The following is a description of a gene set: Human Gene Set: GOBP_HOMOPHILIC_CELL_ADHESION_VIA_PLASMA_MEMBRANE_ADHESION_MOLECULES The attachment of a plasma membrane adhesion molecule in one cell to an identical molecule in an adjacent cell. species: Homo sapiens, and this is the list of marker genes: PCDHB15, DSG1, PCDH18, DSC3, PCDHA9, PCDHB1, PCDHB2, CELSR2, CDH26, PCDH7, FAT3, NECTIN1, PCDHB6, PTPRG, HMCN1, CDH9 (cadherin 9), CDH1 (NCBI Gene Id 999), PCDHB3, PCDHB7, ESAM, PKD1 (NCBI Gene Id 5310), CEACAM5, PCDH19, PCDHGB3, HMCN2, CDH4, CDH17, PCDHB13, IGSF21, CADM2 (cell adhesion molecule 2), PCDHA5, PCDHGC3, PCDHGA1, PCDHGB1, PTK7 (NCBI Gene Id 5754), PCDHA1, NPTN, AMIGO1, CDH5, DSG3, CDH8, PVR, PCDHB5, CDH16, PCDHGA6, PTPN23, PCDH15, PCDHB18P, CEACAM1, CELSR3, CDH3, ROBO2, NECTIN4 (nectin cell adhesion molecule 4), PCDHA4, RET, PCDHGA9, PCDH8, FAT2, CLSTN3 (calsyntenin 3), PCDHB8, NECTIN2, PIK3CB, PCDHGB5, PCDHGA4, CDHR5, PCDHA13, PLXNB3, PCDH10, PCDHGA12, PCDHB16, MYOT, EMB, PCDHB10, PCDHA7, ROBO4, CDH24, PCDHGA11, IGSF11, PCDHGB4, PCDHA6, DCHS1, PCDHA10, PCDHGB6, PCDHAC2, CDH20, CDH6, PCDH12, PCDHGA2, CDH11, KIRREL3, DSC1, ROBO1, DSCAM, CDHR1, CDHR2, CDH13, ROBO3, PECAM1, BSG, PCDHB4, PCDHB9, SDK2, CDH18, PCDHAC1, MYPN, CLSTN2, TENM3, CDH12, PCDHGA7, PLXNB2, CADM4, PCDH1, PCDHB11, CDH10, ITGB1, CDHR4, DSC2, PCDHGA3 (protocadherin gamma subfamily A, 3), CDH23, PCDHGC4, AMIGO2, PCDHB14, CDH2, FAT4, DSG2, FAT1, PCDH9, PCDHA11, DSCAML1, CNTN6, PCDH11X, DSG4, TRO, MPZL2, PCDHGA10, PTPRM, PTPRR, PCDHA8, PCDHA3, IGSF9, CD84, CNTN4, CDHR3, PCDH11Y, PCDH17, SDK1, CDH15, PCDHGA5, CDH22, PCDHGB2, PCDHGA8, PTPRT, CEACAM6, PCDHB12, CNTN2 (NCBI Gene Id 6900), DCHS2, CELSR1, PCDHA12, L1CAM, CLSTN1, NECTIN3, PALLD, PCDHGB7, CADM3, CDH19, CADM1, PCDH20, NEXN, PCDHGC5, CDH7, PCDHA2 (protocadherin alpha 2)